Given this list of marker genes FAM83A, EPS15L1, CSK, AAMP, EGF, ADAM10, SH3KBP1, AREG, SOS1, HRAS, PAG1, GRB2, ADAM12, PXN, ARHGEF7 (Rho guanine nucleotide exchange factor 7), SH3GL1, RPS27A, SPRY1, EREG, EPN1, PTPN12, BTC, TGFA, FAM83D, SH3GL3, ADAM17, PTPN3, SH3GL2, HGS, GAB1, UBB, EPS15, STAM, PIK3R1, SHC1, CBL, PIK3CA, NRAS, FAM83B, PLCG1, CDC42, EGFR, LRIG1, PTPN11, PTPRK, SRC, SPRY2, KRAS, UBA52, HBEGF, EPGN, UBC, STAM2, here is a description of the gene set: part of: Signaling by Receptor Tyrosine Kinases Reactome Pathway: Signaling by EGFR The epidermal growth factor receptor (EGFR) is one member of the ERBB family of transmembrane glycoprotein tyrosine receptor kinases (RTK). Binding of EGFR to its ligands induces conformational change that unmasks the dimerization interface in the extracellular domain of EGFR, leading to receptor homo- or heterodimerization at the cell surface. Dimerization of the extracellular regions of EGFR triggers additional conformational change of the cytoplasmic EGFR regions, enabling the kinase domains of two EGFR molecules to achieve the catalytically active conformation. Ligand activated EGFR dimers trans-autophosphorylate on tyrosine residues in the cytoplasmic tail of the receptor. Phosphorylated tyrosines serve as binding sites for the recruitment of signal transducers and activators of intracellular substrates, which then stimulate intracellular signal transduction cascades that are involved in regulating cellular proliferation, differentiation, and survival. Recruitment of complexes containing GRB2 and SOS1 to phosphorylated EGFR dimers either directly, through phosphotyrosine residues that serve as GRB2 docking sites, or indirectly, through SHC1 recruitment, promotes GDP to GTP exchange on RAS, resulting in the activation of RAF/MAP kinase cascade. Binding of complexes of GRB2 and GAB1 to phosphorylated EGFR dimers leads to formation of the active PI3K complex, conversion of PIP2 into PIP3, and activation of AKT signaling. Phospholipase C-gamma1 (PLCG1) can also be recruited directly, through EGFR phosphotyrosine residues that serve as PLCG1 docking sites, which leads to PLCG1 phosphorylation by EGFR and activation of DAG and IP3 signaling. EGFR signaling is downregulated by the action of ubiquitin ligase CBL. CBL binds directly to the phosphorylated EGFR dimer through the phosphotyrosine Y1069 (i.e. Y1045 in the mature protein) in the C-tail of EGFR, and after CBL is phosphorylated by EGFR, it becomes active and ubiquitinates phosphorylated EGFR dimers, targeting them for degradation. Positive regulation of EGFR signaling by direct association of EGFR with accessory proteins such as AAMP and FAM83B is being investigated. For review of EGFR signaling, please refer to Carpenter 1999, Wells 1999, Schlessinger 2002, Herbst 2004, Avraham and Yarden, 2011, Bartel et al. 2016, Uribe et al. 2021, Keflee et al. 2022. studied in species Homo sapiens